Given this list of marker genes RTTN, DHX16, CPLX1, FLNA, ADGRL1, CDH2, ZNF292, MAN1B1, KAT6B, CPLANE1, INTS8, ZEB2, FAT4, KATNB1 (NCBI Gene Id 10300), DCHS1, NEDD4L, VPS35L, TBC1D24, PRORP, NRCAM, SLC25A24, TMTC3, FMR1, DHCR7, KAT8, ARF1, TUBA1A, MAP1B, CSGALNACT1, C2CD3, RNU4-2, ANKRD11, MAST1, PDHB, ERMARD, ZMIZ1, ZSWIM6, PLCH1, APC2, PLK4, CSF1R, ALDH6A1, ARFGEF2, here is a description of the gene set: studied in species Homo sapiens A form of gray matter heterotopia were the mislocalized gray matter is typically located periventricularly, also sometimes called subependymal heterotopia. Periventricular means beside the ventricles. This is by far the most common location for heterotopia. Subependymal heterotopia present in a wide array of variations. There can be a small single node or a large number of nodes, can exist on either or both sides of the brain at any point along the higher ventricle margins, can be small or large, single or multiple, and can form a small node or a large wavy or curved mass. Human Gene Set: HP_PERIVENTRICULAR_HETEROTOPIA Periventricular heterotopia